The following is a description of a gene set: studied in species Mus musculus Binds to and increases the activity of an ATP hydrolysis activity. Mouse Gene Set: GOMF_ATPASE_ACTIVATOR_ACTIVITY, and this is the list of marker genes: Dnajc24, Tor1aip2, Dnajc19, Dnaja1, Dnajb4, Dnajb1, Atp4b, Atp1b3, Atp6ap1, Ahsa1, Rab6a, Atp1b1, Atp1b2, Hscb, Dnajc15, Dnajc10, Tor1aip1, Grpel1, Rab4a, Gtf2h4, Atp6ap1l, Dnajb2, Dnaja2, Nkrf, Dnajb6, Ahsa2, Rab3a